Given this list of marker genes PSMD14, G0S2, AGK, NDUFS6, CD81, CLIC4, STAC, HPD, NXT2, MINPP1, SLC12A6, SORT1, CMAS, VDAC1, PDK1, UPP1, SERPINE1 (serpin family E member 1), F3, G6PD, FKBP5, YIPF5, C1QBP, INHBA, CETN2 (NCBI Gene Id 812), SLC43A3, BID, PDXK, CXCL1, FBXO34, ACTN1, SRC, EMP1, IL12B, BHLHE40, TTLL4, ATP6V1A, CHST11, CCL1, ZC3H12A, CCL4 (C-C motif chemokine ligand 4), RGCC, BTG3, GPR68, XPO4, EXOSC4, NRIP3, PARK7, ACOX1, ALAS1, IL1RN, HMGA1, GAR1, CHI3L1, UCK2, PDSS1, CCL24, NME1, STAG3, UBE2J1, HEG1, SLC1A3, LAMP3, RAB5IF, CHST2, GSR, NDUFAB1, ZNF207, CEBPB, ALOX5AP, IL3RA, MSC, TNIP3, PDE4DIP, GPX3, TXN, PSMD11, CYCS, NFAT5, BHLHE41, TXK, TFPI2, TMEM38B, SPRED2, FPR2, CCL22, JUN, BCL2A1, FCAR, ASAP1, TMX2, PDPN, CRIM1, MSMO1, SCYL2, GP1BA, NDRG2, MAFF, NCF2, SDC4, ATP5MC3, RIT1, IL1A, SEPTIN11, CYP51A1, DPYD (NCBI Gene Id 1806), TSC22D1, ATP6V1H, TKFC, TNFAIP8, CYP27B1, NUTF2, BCAT1, MARCKSL1, RAB13, ATP13A3, FOSL2, CXCR3, PSMB3, C1orf54, MAP4K4, IDH3A, ALCAM, IL1R2, CCDC86, NOP16, ADO, IL1B, FDX1, MMP7, DLD, PTAFR, IL36G, TMED9, KMO, CD80, IGSF6, SPP1, VIM, FGR, ARFGAP3, ENO1, PTPN12, KCNN4, PMEPA1, NIP7, IL2RG, TUBB6, BMAL2, SC5D, SENP7, PLAUR, ABHD2, TNFRSF4, SS18 (NCBI Gene Id 6760), RAB33A, CA2 (carbonic anhydrase 2), SLC16A3, CXCL8, GSN, ITGAM, IL2RB, CSTB, ALOX15B, FSCN1, CXCL13, MREG, METTL1, GATAD2A, IL6, RASAL2, LRP12, ATP6AP1, EPB41, SLC2A3, PPIF, MDM4, EBI3, CXCL3, CYC1, CLIC3, MARCHF3, EPB41L2 (NCBI Gene Id 2037), SMURF1, OLR1, CORO1C, TNIP1, CCL13, PSMC3, QPCT, RELB, SLAMF8, LPL, NFKB2, DDA1, FBP1, PPA2, DNPH1 (2'-deoxynucleoside 5'-phosphate N-hydrolase 1), RASA3, AIRIM (NCBI Gene Id 54955, AFG2 interacting ribosome maturation factor), here is a description of the gene set: We identified Pparg as a major orchestrator of the phenotype of adipose-tissue resident regulatory T cells (VAT Tregs). To explore the contribution of Pparg1 and 2 in the generation of the VAT Tregs-specific gene signatures, CD4+FoxP3- T cells were transduced with Foxp3+/- Pparg1 (or Pparg2), treated with Pioglitazone or vehicle, and double sorted for microarray analysis. Genes up-regulated in CD4 T cells over-expressing FOXP3 and Pparg1 isoform of PPARG: untreated versus pioglitazone. from publication Cipolletta D, Feuerer M, Li A, Kamei N, Lee J, Shoelson SE, Benoist C, Mathis D (PMID 22722857) studied in species Homo sapiens Human Gene Set: GSE37533_UNTREATED_VS_PIOGLIZATONE_TREATED_CD4_TCELL_PPARG1_AND_FOXP3_TRASDUCED_UP